The following is a description of a gene set: Diminished amniotic fluid volume in pregnancy. Oligohydramnios Human Gene Set: HP_OLIGOHYDRAMNIOS studied in species Homo sapiens, and this is the list of marker genes: WBP4, NALCN, ZMPSTE24, FANCM, CDKN1C, PIGW (NCBI Gene Id 284098), FREM2, TXNDC15, GREB1L, WNT4, BRCA2, PBX1 (NCBI Gene Id 5087), CA2, CRELD1, FANCC, GLI3, DHPS, TMEM231, MAD2L2, COL25A1, PKHD1, FANCA, ASCL1, ALG8, ACTG2, MBTPS2, TCTN1, PWRN1, AGT, ZFX, BMPER, ALX4, XRCC2, ALB, DZIP1L, ALG9, EXOSC9, RHCE, RNU4ATAC, NPHP3, CERT1, FANCF, H19, EFEMP2, NPAP1, PDX1, MYL9, PGAP3, RNF2, NEK9, ATN1, HMGA2, SETD1A, ITGA8, SATB1, TBCK, TCTN3, COQ7, CDC42BPB (CDC42 binding protein kinase beta), HSPA9, REN, RHD (NCBI Gene Id 6007), PALB2, RET, FANCD2, PIGL, FARSB, BNC2, FGF20, INVS, DEF6, FANCL, BRCA1 (NCBI Gene Id 672), B3GALT6, LARS2, PAX2, TCTN2, PWAR1, IFIH1, CPT2, B9D1, PLAG1, GNB2, ACE, COG5, GFRA1, HS2ST1, RBM10, PLAGL1, ERCC4, MYH11, TMEM216, PUF60, B9D2, SCYL2, VPS33B, SV2A, ERGIC1, SLC25A24, BRIP1, LIFR (NCBI Gene Id 3977), SLC35A2, MKRN3, CSPP1, WDR73, CEP290, GMPPB, FXR1, TMEM237, GRIP1, INPPL1, NDUFA6, MTO1 (mitochondrial tRNA translation optimization 1), CC2D2A, KIF14, MAGEL2, RHAG, SEC24D, FBN1, TMEM70, FILIP1, NAA10, ATP6V1E1, LAMB2, FBLN5, NEK8, CLTCL1, TMEM107, FANCI, IGF2, SFXN4, TMEM67, SZT2, DALRD3, DSP, TALDO1, HBA1, DPF2, FANCE, DONSON (NCBI Gene Id 55597, DNA replication fork stabilization factor DONSON), TPI1, HYMAI, GNPTAB, FARSA, SNORD115-1, MYLK, SNORD116-1, PHOX2B, OSGEP, HBA2, RAD51C, TRIP4, COX14, BIN1, PIGO, UBE2T, GATA6, MYH3, SNRPN, FANCB, C1QBP, PGAP2, IARS1, HERC2, RPGRIP1, POR, BUB1B, RFWD3, DYRK1A, HNF1B, PIGV, UQCC2, SLX4, MKS1, WNT9B, JUP, AGTR1, DDX6, SEC61A1, DOCK6, UBE2A, LHX1, RPGRIP1L, RAD51, AMER1, FRA10AC1, NDUFB7, EBF3, CEP55, PIGY (phosphatidylinositol glycan anchor biosynthesis class Y), CHRM3, FANCG